The following is a description of a gene set: Long nasal bridge Human Gene Set: HP_LONG_NASAL_BRIDGE species: Homo sapiens Increased superior-inferior length of the nasal bridge, which is the saddle-shaped area that includes the nasal root and the lateral aspects of the nose., and this is the list of marker genes: TPM2 (NCBI Gene Id 7169), BPTF, PSMC1, MYH3, SEPTIN9 (septin 9)